The following is a description of a gene set: from publication Chen Y, Wang X (PMID 31504780) Human Gene Set: MIR4254 species: Homo sapiens Genes predicted to be targets of miRBase v22 microRNA hsa-miR-4254 in miRDB v6.0 with MirTarget v4 prediction scores > 80 (high confidence targets)., and this is the list of marker genes: IGSF6, NKD1, BDH2, ARHGAP25, PCDH11Y, GPAT4, PAX5, LAMB3, UROS, GABRB2, DLX3, TRIR, TMCC2, WBP1L, CHMP7, POT1, DNER, CAMK1G, UBA6, AJUBA, PSMA5, CENPT, KIF2A, TSNARE1, C10orf105, KDM3B, HOMER1, LIN28A, EPHB2, TBC1D13, PIGK, MGAT5B, CELF5, PPP1R14C, SIPA1L3, ACTR2, CSRNP2, ASB10 (ankyrin repeat and SOCS box containing 10), PARP1, KIT, ANKRD13B, SLC26A10P, RNASEH2B, MID1, CDH24, MICU1, BEND6, DOCK3, GNG7, ZNF470, DTNB, KLRF1, KHNYN, LY6H, GPD1, ZDHHC11, DENND5B, KDM6A, LRRC14, SEL1L, BSPRY, FSCN3, SSC4D, URM1, SH3RF2, RHOBTB2, CD44, ARRB1, TSPAN18, SLC38A1, IYD, DNAJC25, TMEM87A, ZNF780B, SPOUT1, IGF2BP1, HPS4, OSBP2, CTDSPL2, SHISA6, HBEGF (heparin binding EGF like growth factor), CD1D, PLA2G2F, PHC2, CHST11, ADGRG5, CD300C, CUZD1, PKIA, PPP1R12B, FAM131B, CA10, CHD1, SHISA7, PTGFRN, BTN3A1, MINK1, SAMD11, SCYL3, KMT2D